Given this list of marker genes Gm20914, Phf20l1, Setd5, Spin4, Ing2 (NCBI Gene Id 69260), L3mbtl1, Eed, Gm21310, Spin2-ps10, Psmd4, Spin2c, Spin2e, Rad23b, Gm20826, Glyr1, Optn, Phf19, Gm20873, Rnf31, Gm20773, Chd1l, Gm21812, Nploc4, Sprtn, Dzip3, Cdyl2, Kmt2a, Hspd1, Gm20795, Gm20822, ENSMUSG00000121958 (novel spindlin family protein), Stat3 (signal transducer and activator of transcription 3), Trp53bp1, Pou5f1, Yeats2, Lyn, Jmjd7 (NCBI Gene Id 433466), Hdac6, Brdt, Rnf169, Spin2-ps1, Ubqln1, Spin2-ps7, Topbp1, Gm21292, Zfand6, Agap3 (ArfGAP with GTPase domain, ankyrin repeat and PH domain 3), Ank2, Ubqln3, Otud7b, Macroh2a1, Dppa3, Abraxas2 (NCBI Gene Id 78866), Mllt1, Brd9 (bromodomain containing 9), Morc4, Tnip1, Brcc3dc, Kdm8, Gm20807, Baz2a, Nbn, Ssty1, Ubqln2, Spin2g, Mindy2, Tnip2, Smarca4, Pygo1, Mtf2, Xrcc1, Parp10, Ncapd3, Gm21719, Cgas, Gm20818, Zzef1, Sqstm1, Socs7, Bag6, Ufd1, Afg2b, Mbtd1, Gm20830 (predicted gene, 20830), Ubxn1, Ank3, Suz12, Eps15, Mpnd, Thap7, Ubqln4, L3mbtl2 (L3MBTL2 polycomb repressive complex 1 subunit), Gm20815, Brd3, Ikbkg, Chd8, Ywhag, Cbx5 (NCBI Gene Id 97945), Nanog (Nanog homeobox), Gm20812, Ascc2, Dpf2, Sgf29, Spin2-ps8, Psme4, Brd7, Ncapg2, L3mbtl3, Faap20, Kmt2e, Vcp, Gm20865, Pwwp2a, Uhrf1, Cbx6, Rad18, Zranb1, Atrx, Plcg2, Taf1, Ssty2, Zmynd11, Rad23a, Ubqln5, Gm20816 (predicted gene, 20816), Ep300, Ubac1 (NCBI Gene Id 98766), Spin2j, Cbx1, Ptpn6, Babam2, Prpf8, Tnip3, Vav1, Gm20808, Wdr81, Brcc3, Mphosph8, Ing3, Tab2, Ikbke, Agl, Cbx2, Phf1, Gm28171, Ubqlnl, Phf2, Tab3, Spin2-ps3, Cxxc1, Rnf168, Ing5, Msl3, Atad2b, Otud7a, Htatsf1, Gm20917, Gm20825, Zzz3, Rrp8, Gm20737, Cbx3, Phf8, Rag2, Parp2, Gm21854, Kdm5a, Spin1, Ing4, Cbx8, Hdgfl2, Atrip, Gm20918, Gm20852, Brd2 (NCBI Gene Id 547337), Phip, Morc3, Ubl7, Gm20821, Phf13 (PHD finger protein 13), Uimc1, Gm20747, Abraxas1, Gm21394, Gm20806, Mllt3, Spin2-ps9, Kdm7a, Gm21118, Dnajb2, Tnfaip3, Socs2 (suppressor of cytokine signaling 2), Chd1, Msh6, Bptf, Spin2-ps4, Kdm4a (lysine (K)-specific demethylase 4A), Zranb3, Wdr5, Zmynd8, Tom1, Mindy1, Brd4, Gm20834, Cdyl, Ing1, Zcwpw1, Yeats4, Zbtb1, Carm1, Aplf, Gm20854, Fmr1, Zcwpw2 (zinc finger, CW type with PWWP domain 2), Tdrd3, Sharpin, Zfand2b, Spin2-ps2, Lrwd1, Trim24, Spin2d, Spin2h, Sirt1, Gm20738, here is a description of the gene set: Mouse Gene Set: GOMF_MODIFICATION_DEPENDENT_PROTEIN_BINDING Binding to a protein upon post-translation modification of the target protein. studied in species Mus musculus